The following is a description of a gene set: species: Mus musculus Mouse Gene Set: REACTOME_ENOS_ACTIVATION eNOS activation, and this is the list of marker genes: Hsp90aa1, Zdhhc21, Ddah1, Spr, Cav1, Nos3, Lypla1, Cyb5b, Calm2, Calm1, Cygb, Calm3, Akt1